The following is a description of a gene set: Human Gene Set: GOBP_POSITIVE_REGULATION_OF_HORMONE_SECRETION Any process that activates or increases the frequency, rate or extent of the regulated release of a hormone from a cell. studied in species Homo sapiens, and this is the list of marker genes: VSNL1, UCN3, HIF1A, BAIAP3, HLA-DRB1, PLCB1, ITSN1, ITPR1, NKX6-1, SMAD4, PRKAR1A, PRKD1, SCT, GCK, RFX6, CD38, C2CD2L, GHRH, DYNLL1, PDX1, PCK2, AIMP1, AACS (NCBI Gene Id 65985), FOXL2, SOX11, MYB, RBP4, GCG, SERP1, TAC1, PSMD9, PRKCE, EDN3, BLK, MLXIPL, NADK, DOC2B, PFKFB2, IRS2, SELENOT, FGB, SIRT6, SPP1, TFR2, GALR1, GHRHR, CAPN10, PLA2G6, BMP6, GRP, ANO1, ABCC8, GPR68, GHRL, SLC30A8, TNFSF11, PLA2G3, BAD, GLUD1, C1QTNF1, ISL1, PRKCA, VAMP8 (vesicle associated membrane protein 8), TRPM5, OXCT1, LEP, FFAR1, FGFR1, JAK2, ORAI1, CREB1, SIRT3, FFAR4, UCN, GIP, TMF1, RAPGEF4, NLGN2, ADCYAP1, GAL, CRH, INHBA, GPLD1, LRRC8A, GNA11, FGG, NR1H4, RAB8B (RAB8B, member RAS oncogene family), TCF7L2, TUNAR, RPH3AL, GPER1, PFKM, MCU, MPC2, APLN, RETN, PPARG, INS, MYRIP, F2, PRKN, PPARD, TARDBP, STX4, NKX3-1, FGA, CYP19A1, PHPT1, NMU, SLC2A2, C1QTNF3, P2RY1 (purinergic receptor P2Y1), ILDR1, PRKCB (protein kinase C beta), PRKACA, CFTR, GPRC6A, CASR, SNX4, GPR27, NR0B2, GABBR1, NMB, TRPM4, TM7SF3, F2RL2, ADCY8, PPP3CB, GIPR, C1QTNF12, ABAT, CHRM3, OSBP, NNAT, INHBB, VAMP7, ECRG4, SOX4, DRD2, INHA, RAC1, ACSL4, TRH, HFE, HCAR2, DAB2, TRPA1, FFAR2, EDN1, TACR1, RASL10B (RAS like family 10 member B), SYBU, PTPN11